The following is a description of a gene set: from publication Yang HT, Wang Y, Zhao X, Demissie E, Papoutsopoulou S, Mambole A, O'Garra A, Tomczak MF, Erdman SE, Fox JG, Ley SC, Horwitz BH (PMID 21217011) species: Homo sapiens Human Gene Set: GSE19941_LPS_VS_LPS_AND_IL10_STIM_IL10_KO_MACROPHAGE_DN Bone marrow-derived macrophages were produced from mice lacking IL-10 alone (IL10-def) or mice lacking both IL-10 and the p50/p105 subunit of NF-kB (p50/IL10), and left unstimulated, stimulated with LPS (1 ng/ml) or stimulated with LPS and IL-10 (0.3 ng/ml). Genes down-regulated in IL10 knockout macrophages stimulated by LPS versus those also stimulated by IL10., and this is the list of marker genes: SLC17A9, PRPF38B, NNT, LDAF1, GAS5, IL15, LAD1, UNC5A, CMC1, HERC3, SEZ6L2, USP32, IQCB1, CTLA4, WFDC9, SNORA41, WDTC1, GPR183, TSC22D2, PPP4C, PSEN2, ST14, DAPL1, PBX3, PELI1, FARP1, PRKCH, IFI44, FGF13, UNC5CL, FAM3C, AIM2, MBOAT1, SLC6A19, CBX7, WLS, VGLL1, PDK2, BEND4, LPCAT2, NEURL3, CORO2A, SLC25A5, PTPN13, CASP4, TACC2, AQP3, SLC1A1, RAPGEF6, FOXA3, MARCHF3, UST, RNF122, EXOC6, MAN2A2, ATP6V1G3, UBXN11, CYRIA, SIDT2, CD79B, HPS3, GUCY1A1, WFIKKN2, APOBEC2, LY6E, CYP2R1, APP, MAP3K5, LILRB4, WNT5B, ZC3H12D, CAMSAP2, ST6GAL1, LY75, ARHGEF12, EML4, CD86, ENTPD4, EFL1, ELL2, GPR155, TTN, RAB4A, FHL3, LYSMD2, USP31, NCF1, PKP4, EPS8L1, LITAF, FSCN2, KLK8, VPS13B, TCEAL1, TNFSF15, GPR174, ALDOC, SYTL1, LCLAT1, RNF123, MIR15A, MGMT, PROS1, ARHGAP27, FCHO2, PNLDC1, GRAMD4, CD72, DMRT3 (NCBI Gene Id 63949), VPS13A, PGC, ATP1B1, CIMIP2B, TSHZ3, DEFB130A, IL17F (NCBI Gene Id 112744), INSIG1 (NCBI Gene Id 3638), CAMTA1, CPQ, PPIC, PID1, EIF4A2, ILDR1, EPHA3, IL6R, SH3RF3, FILIP1L, GPR25, N4BP2L1, FAAH, CPEB2, ALCAM (NCBI Gene Id 214), LALBA, TENT5A, EPHA1, NT5E, MYADM, TANC2, SNTB1, TRARG1, MYO3B, ENTREP3, GPRC5C, ODC1, CXCR5, CALY, SELL, AKT3, TMEM171, STK39, ADGRG5, CNR2, TCTA, CHIC1, TENT5C, IQSEC1, CDK8, PGLYRP1, MIR92B (microRNA 92b)